The following is a description of a gene set: species: Homo sapiens Genes in the most frequently homozygous deleted loci in a panel of glioma cell lines. from publication Roversi G, Pfundt R, Moroni RF, Magnani I, van Reijmersdal S, Pollo B, Straatman H, Larizza L, Schoenmakers EF (PMID 16247447) Human Gene Set: ROVERSI_GLIOMA_COPY_NUMBER_DN Identification of genetic copy number changes in glial tumors is of importance in the context of improved/refined diagnostic, prognostic procedures and therapeutic decision-making. In order to detect recurrent genomic copy number changes that might play a role in glioma pathogenesis and/or progression, we characterized 25 primary glioma cell lines including 15 non glioblastoma (non GBM) (I-III WHO grade) and 10 GBM (IV WHO grade), by array comparative genomic hybridization, using a DNA microarray comprising approx. 3500 BACs covering the entire genome with a 1 Mb resolution and additional 800 BACs covering chromosome 19 at tiling path resolution. Combined evaluation by single clone and whole chromosome analysis plus 'moving average (MA) approach' enabled us to confirm most of the genetic abnormalities previously identified to be associated with glioma progression, including +1q32, +7, -10, -22q, PTEN and p16 loss, and to disclose new small genomic regions, some correlating with grade malignancy. Grade I-III gliomas exclusively showed losses at 3p26 (53%), 4q13-21 (33%) and 7p15-p21 (26%), whereas only GBMs exhibited 4p16.1 losses (40%). Other recurrent imbalances, such as losses at 4p15, 5q22-q23, 6p23-25, 12p13 and gains at 11p11-q13, were shared by different glioma grades. Three intervals with peak of loss could be further refined for chromosome 10 by our MA approach. Data analysis of full-coverage chromosome 19 highlighted two main regions of copy number gain, never described before in gliomas, at 19p13.11 and 19q13.13-13.2. The well-known 19q13.3 loss of heterozygosity area in gliomas was not frequently affected in our cell lines. Genomic hotspot detection facilitated the identification of small intervals resulting in positional candidate genes such as PRDM2 (1p36.21), LRP1B (2q22.3), ADARB2 (10p15.3), BCCIP (10q26.2) and ING1 (13q34) for losses and ECT2 (3q26.3), MDK, DDB2, IG20 (11p11.2) for gains. These data increase our current knowledge about cryptic genetic changes in gliomas and may facilitate the further identification of novel genetic elements, which may provide us with molecular tools for the improved diagnostics and therapeutic decision-making in these tumors., and this is the list of marker genes: ZEB2, DHX32, CETP, ITIH5 (NCBI Gene Id 84903), KIN, BBS2, PTEN (phosphatase and tensin homolog), BCCIP (BRCA2 and CDKN1A interacting protein), SFTPA2, KYNU, NUDT21, LRP1B, UROS, TAF3, MKI67, PRDM13, ARHGAP15, TAFA5 (TAFA chemokine like family member 5), ARHGEF7, CPNE2, CCNC, FBXL4, SFMBT2, KLHL32, CDKN2A, CTBP2, HERPUD1, ITIH2, NUTM2A, TUBGCP3 (tubulin gamma complex component 3), ATP5F1C, NXPH2, KCNMA1, MMP21, ARL2BP, GPR63, FANK1, SFTPD, ADAM12, HNMT, SOX1, ANKRD10, ING1, DOCK1, PTPRE, ANXA11, PSME3IP1, CES1, SFTPA1, GNAO1, FHL5, POU3F2, COQ3, AMFR